Given this list of marker genes TCF21, OSR1, AQP1, CD34, PDGFRA, EGR1, WT1, PDGFRB, PDGFB, here is a description of the gene set: Human Gene Set: GOBP_METANEPHRIC_GLOMERULUS_VASCULATURE_DEVELOPMENT The biological process whose specific outcome is the progression of a metanephric glomerulus vasculature from an initial condition to its mature state. This process begins with the formation of the metanephric glomerulus vasculature and ends with the mature structure. The metanephric glomerulus vasculature is composed of the tubule structures that carry blood or lymph in the metanephric glomerulus. species: Homo sapiens